Given this list of marker genes Hopx, Pfkl, Akr1c19, Tmprss2, Ndufs2, Trpm2, Sult1c2, Fbp1, Cdhr2, Cdh8, Adh1, Ppp1r1a, Frk, Pkhd1, Slc12a7, Cpn1, Sfxn2, Slc40a1, Dpp4, Cltrn, Pamr1, Glul, Pou3f4, Vldlr, Tat, Tm4sf4, Cdo1, Me3, Slc26a1, Bcl6b, Prlr (NCBI Gene Id 19117), Proc, Fbp2, Golt1a, Adam32, Mlxipl, Cyp4v3, Pigr, Rnase4, Akr1c13, Anxa4, Tmprss4, Fh1, Pfkfb2, Slc37a4, Pdk1, Slco1a6, Pcsk9, Slc38a4, Ambp, Ppp4r1l-ps, Glp1r, Hpgds, Trpm5, Pklr (NCBI Gene Id 18770), Hnf4a, Sult1d1, Atp4a, Sema4a, Hcar2, Kif12, Atp7a, Sgk2, Nptx2, Ffar2, Tmed6, Cox6a2, Serpina10, Foxa3, Fxyd3 (FXYD domain-containing ion transport regulator 3), Cpb2, Enpep, Alox12e, Anks4b, Gng12, Igf1r, Dct, Tacr3, Meltf, Muc4, Ace2, Pcsk1, Ddc, Msh5, Gatm, Vil1, Slc2a2, Col27a1, Rnf186, G6pc2, Ugt1a1, Cbs, Mapk15, Mtmr11, Ttr, Ugt2b35, Clic5, Etv5, Tpi1 (NCBI Gene Id 21991), Kyat3, Pfkp, Grtp1, Kdm2b, Elovl2, Pgk1, Ccl28, Gc, Hgfac, Ugt2b34, Akr1c12, Nr1h4, Rab37, Gpr137b, Wnk4, here is a description of the gene set: Heterozygous HNF1A mutations cause pancreatic-islet beta-cell dysfunction and monogenic diabetes (MODY3). Hnf1alpha is known to regulate numerous hepatic genes, yet knowledge of its function in pancreatic islets is more limited. We now show that Hnf1a deficiency in mice leads to highly tissue-specific changes in the expression of genes involved in key functions of both islets and liver. To gain insights into the mechanisms of tissue-specific Hnf1alpha regulation, we integrated expression studies of Hnf1a-deficient mice with identification of direct Hnf1alpha targets. We demonstrate that Hnf1alpha can bind in a tissue-selective manner to genes that are expressed only in liver or islets. We also show that Hnf1alpha is essential only for the transcription of a minor fraction of its direct-target genes. Even among genes that were expressed in both liver and islets, the subset of targets showing functional dependence on Hnf1alpha was highly tissue specific. This was partly explained by the compensatory occupancy by the paralog Hnf1beta at selected genes in Hnf1a-deficient liver. In keeping with these findings, the biological consequences of Hnf1a deficiency were markedly different in islets and liver. Notably, Hnf1a deficiency led to impaired large-T-antigen-induced growth and oncogenesis in beta cells yet enhanced proliferation in hepatocytes. Collectively, these findings show that Hnf1alpha governs broad, highly tissue-specific genetic programs in pancreatic islets and liver and reveal key consequences of Hnf1a deficiency relevant to the pathophysiology of monogenic diabetes. Genes down-regulated in pancreatic islets upon knockout of HNF1A. studied in species Mus musculus from publication Servitja JM, Pignatelli M, Maestro MA, Cardalda C, Boj SF, Lozano J, Blanco E, Lafuente A, McCarthy MI, Sumoy L, Guigó R, Ferrer J (PMID 19289501) Mouse Gene Set: SERVITJA_ISLET_HNF1A_TARGETS_DN